The following is a description of a gene set: from publication Chen Y, Wang X (PMID 31504780) Genes predicted to be targets of miRBase v22 microRNA hsa-miR-32-3p in miRDB v6.0 with MirTarget v4 prediction scores > 80 (high confidence targets). species: Homo sapiens Human Gene Set: MIR32_3P, and this is the list of marker genes: ARIH1 (ariadne RBR E3 ubiquitin protein ligase 1), SEMA3A, MAP3K8, KAZN, TM6SF1, ECSCR, REXO4, PIAS1, SLC25A33, TBC1D23, SCRN1, OXR1, STOX2, NDNF, NUP205, NDFIP2, PIP4P2, CXADR, HOOK3, ARHGEF28, STRN, KIF11, KLF5, PAPOLA, SMC5, CCDC125, KRAS, MKX, ZC3H6, OSBP, KIAA1143, PREX2, SGPP1, HPS5 (NCBI Gene Id 246309), GABPA, SGMS1, CARNMT1, ACBD5, FEM1B, UTP25, STAG2, DACT1, SMNDC1 (NCBI Gene Id 10285), SRGAP1, MMAA, STRADB, CD58, PACC1, RORA, KCTD9, ANKRD28, MAP3K21, RNF141, PI15, INPPL1, SAMD8, MED13, NCOA2, TMEM108, USF3, ZDHHC21, LRRTM3, BRWD3, ABHD13, DPP10, PTPN4, CAPRIN1, POM121, DAAM1, RGPD1, CAB39, PCDH19, TBC1D32, ARHGEF3, CIP2A, KCNQ5, EMC7, SENP2, ANK3, VPS72, JPT2, TNFAIP3, SRRM1, STAT3, CNKSR2, BDH2, NHLRC2, TSHZ3 (teashirt zinc finger homeobox 3), CAAP1, ARL5A, DOCK5, QKI, HPCAL1, FBN1, ZNF215 (zinc finger protein 215), VWA3B (NCBI Gene Id 200403), SLK, NEK10, EFEMP1, MINDY2, TIPRL, CSN1S1, NPHP1, PDZRN3 (PDZ domain containing ring finger 3), ATP1B1, DMRTA1, NRIP1, FERMT2, HAPLN1, JADE3, CMPK1, SPIRE1, MTM1, PDE10A, YOD1, EIF4E3, PPP1R8, KPNA4, CFHR3, MMS22L, SIMC1, CFHR4, SYNJ2BP, SH3BP4, CADPS, NR4A3, CORO2A, DTNA, PTPN12, LIMK2, RNGTT, MKLN1, PPP2CB, ZBTB10, NAA30, TNPO1, DPH3P1, GOLPH3, HTR2A, YTHDC2, USP37, CAV2 (caveolin 2), HYAL2, SEC61G, PLCL1, SEPSECS, LSM8, CALD1, SOCS6, UBA5, NEXMIF, BBX, ITGB6, FAM8A1, USP32, PDCD10, PRKCI, CNOT7, MAPKAPK5, GPC5, PAFAH1B1, ACOT13, EYA4, NGF, GUF1, TCIM (NCBI Gene Id 56892), ITGB8, GORASP2, CLVS1 (clavesin 1), TRIM33, CAPS2, ME2, STX7, ACTN2, XK, TTC28, MYBL1, MBNL2, LMAN1, SAMTOR, C1QBP, NAV3, LIN54, ATP5F1C (ATP synthase F1 subunit gamma), USP24, LILRA1, KLHL7, SNX18, CACNA1G, NRAS, PDE8B, NDUFA5, MOB1A, DDX3Y, INO80D, FUT9, VLDLR, XRN1, ATF1, APP, PPP1R15B, ITPRIPL2, SRSF6, FOXG1, PCM1, TAPT1, JAM3, AMACR, AIFM1, C21orf91, NTF3, GDF10, USP30 (NCBI Gene Id 84749), C5orf47, FLG, ADAMTS6, ZDHHC17, LIN28B, KIAA1549L, MINDY3, CDIN1, PLEKHF2, PPP2R2A, CELF2, PEG10 (paternally expressed 10), CDK6, NAALADL2, ALKBH1, HEATR5A, GNPTAB, PAXIP1, F13B, TYW3, TRDMT1, THBS2, SEC24D, RBMS3 (NCBI Gene Id 27303), PLS1, PRPF40A, L3HYPDH, SLC37A3, CHMP4C, LATS2, UBE2S, CNOT6L, ATRX, MIA2, USP8, BRPF3, ZIC1, STXBP5, KBTBD3, PREX1, JADE1, COL1A2, FBXO28, KLHL2 (NCBI Gene Id 11275), TIPARP, NPAS2, PDE3A, SENP7, HAND2, KCNK9, STEAP2, CREBL2, BCL11B, SMG1, RP2, STK17B, IRS1, EPC1, CPNE3, ONECUT2, PPP6C, CPNE4 (NCBI Gene Id 8902), KNSTRN, YWHAE, MMD, SKIL, CISD1, RNF217, LYN, SLC36A4, SERPINB4, SCAI, UBTD2, MAP3K20, SGIP1, SERPINB3, GABARAPL2, ASB8, TMTC2, ANKRD39, NR3C2 (nuclear receptor subfamily 3 group C member 2), MYCBP2 (MYC binding protein 2), FGF4, PSMD7, MNX1, TRMT5, NDUFS1, TMEM196, FAM210B, TMEM174, CD44, SLC2A12, TET2, LARP4B, USP12, ACER3, C4orf3, LAMA4, KCTD13, PPM1D, CNEP1R1, PHYKPL, SLC38A1, TWF1, BRWD1, MEIOC, RSBN1, ATP11B, PTAR1, KDM7A, MIGA1, PPARGC1A, CREBZF, TEAD1, AHR, XPO1, SLC66A3, CNIH1, EIF3A, GK, EP300, OLFM3, KIF5B, TGFBR1, PPP4R2, RAB21, SLIT2, ACVR2A